The following is a description of a gene set: studied in species Mus musculus The side (leaflet) of the endosome membrane that faces the cytoplasm. Mouse Gene Set: GOCC_CYTOPLASMIC_SIDE_OF_ENDOSOME_MEMBRANE, and this is the list of marker genes: Micall1, Rab5a, Cdip1, Litafd, Litaf, Rab21, Snx5